The following is a description of a gene set: Genes up-regulated in dendritic cells (12 days): control versus 25-hydroxyvitamin D3. Human Gene Set: GSE13762_CTRL_VS_125_VITAMIND_DAY12_DC_UP We have carried out global gene expression analysis to clarify the interrelationship between 1,25-dihydroxyvitamin D3 and differentiation-driven gene expression patterns in developing human monocyte-derived dendritic cells. Monocytes were treated with 10 nM 1,25-dihydroxyvitamin D3 or vehicle 14 hours after plating for 12 hours or 5 days. Monocytes, differentiating dendritic cells (+/-1,25-dihydroxyvitamin D3 for 12 hours) and immature dendritic cells (+/-1,25-dihydroxyvitamin D3 for 5 days) were harvested. This design allows one to identify genes regulated by differentiation and/or 1,25-dihydroxyvitamin D3 in human monocyte-derived dendritic cells. studied in species Homo sapiens from publication Széles L, Keresztes G, Töröcsik D, Balajthy Z, Krenács L, Póliska S, Steinmeyer A, Zuegel U, Pruenster M, Rot A, Nagy L (PMID 19201860), and this is the list of marker genes: ATAD5, HDAC1, PLEKHA3, RAB7A, HSPA5, MYO1G, ENOX2, DPY19L4, PPIA, PHACTR4, FAM168A, GPR55, HECTD2, HNRNPLL, P2RX7, DTX3, COQ8B, RAD50, NIPSNAP3B, NOP14 (NCBI Gene Id 8602), CEP192, ZSCAN12, FAM83E, EMC3, CENPJ, HNF1B, DHPS, TPK1, BLTP3B, SLC20A2, KRT19, XRRA1, LILRB4, CENPF, CHRNA4 (cholinergic receptor nicotinic alpha 4 subunit), GSPT1, CHRDL1, SPEF2, MIS12, DDX21, ABO, NBEA, TMEM237, CYSLTR2 (cysteinyl leukotriene receptor 2), MAGT1, GLIS1, NOP56, MDFIC, API5, THUMPD3, ARL5A, ULK3, CFC1, NF1, PPM1L, DUSP23, SLC38A2, CEP170, SCN7A, NEB, PLCB4, HCRTR2, UTP6, NOL10, HSPA4L, KCNK4, TNFSF9, ADAMTS6, CCDC122, BID, SULT1B1, LANCL3, ABCA7, AFG3L2, DNALI1, FZD9, GPR83, FUT1, AHRR, MYBL2, ISG20, TMEM47, ZIK1, CRADD, ACOD1, ODF4, ST8SIA2, ZC3HAV1L, ALG8, LCP1, TYR (tyrosinase), VIT, SFTPA1, RHO, CD200R1, CUL2, PSIP1, NELL1, SERPINA7 (serpin family A member 7), BRCA2, PKHD1L1, HSD3B1, CPEB2, POLK, KIF20B, GAS2L2, STARD13, NR4A1 (nuclear receptor subfamily 4 group A member 1), PCDHB13 (NCBI Gene Id 91491), NEPNP, STXBP6 (syntaxin binding protein 6), ME1, STOX1, PHC3, LGI1, SHISAL2A, CENPE, TRIML2, SLC35A3, B3GNT6, STX12, APAF1, PAX1, ZNG1A, KCNK10, UXS1, VNN1, MDM2, TIAL1, SEC24A, SLC25A53, CFB, EPOR, GREM1, LDB2, ANKRD13D, ATF6 (NCBI Gene Id 22926), ZSCAN29, KRT80 (keratin 80), SHISA4, TERB1, IPO7, PRR36, MIGA1, LRP2, GLB1L3, FGF9, GNG5